The following is a description of a gene set: species: Homo sapiens Human Gene Set: GOBP_NEGATIVE_REGULATION_OF_B_CELL_RECEPTOR_SIGNALING_PATHWAY Any process that stops, prevents, or reduces the frequency, rate or extent of signaling pathways initiated by the cross-linking of an antigen receptor on a B cell., and this is the list of marker genes: PLCL2, FCRL3, CD22, GPS2, CD72, FCGR2B, LPXN, PTPN6, CD300A, MIR34A